Given this list of marker genes Sphk2, S1pr3, S1pr1, Gpr6, S1pr5, S1pr4, S1pr2, Gpr3, Sphk1, here is a description of the gene set: studied in species Mus musculus Mouse Gene Set: GOMF_SPHINGOSINE_1_PHOSPHATE_RECEPTOR_ACTIVITY Combining with the sphingolipid sphingosine-1-phosphate (S1P), and transmitting the signal across the membrane by activating an associated G-protein.